The following is a description of a gene set: Genes containing one or more binding sites for (ZNF302) in their promoter regions (TSS -1000,+100 bp) as identified by GTRD version 20.06 ChIP-seq harmonization. from publication Yevshin I, Sharipov R, Kolmykov S, Kondrakhin Y, Kolpakov F (PMID 30445619) Human Gene Set: ZNF302_TARGET_GENES species: Homo sapiens, and this is the list of marker genes: SNHG30, PAXBP1 (PAX3 and PAX7 binding protein 1), EPCIP-AS1, CASC3, FOXM1, STAT6